Given this list of marker genes TMEM241, CHEK1, TROAP, GINS1, PKIB, INCENP, SLC22A5, POLE2, DSCC1 (DNA replication and sister chromatid cohesion 1), TMPO, SULF1, SPAG5, PRC1, CIT, TMEM120B, BRI3BP, BIRC5, CENPJ, NME1, CDCA7, FIGNL1, MASTL, CNIH2, WDHD1, NXNL2, CBX5, MYBL1, AURKA, MRE11, DEGS2, MMS22L, MAP6D1, ASPM, NCAPD2, LSM4, HAUS8, CD320, H2AX, ZWILCH, KCNK5, SIAH2, LYPD6, ESPL1, STIL, MYB, NCAPG2, H1-2, NEMP1, NFATC2, E2F8, XYLB, CIP2A (cellular inhibitor of PP2A), TOP2A, BCL2, CTSD, ELOVL2, KIF23, CDCA4, L2HGDH, KIFC1, SLC39A6, TFDP1, TFAP4, CEP85, NCAPH2, PDSS1, POLD3, JAK2, SYTL5, CDC45, KRT13, FANCG, FANCI, FEN1, MICB, STC2, EXOSC5, BLM, BUB1B, CDK1, RNASEH2A, TMED8, TICRR, ATAD5, CEP55, RFC5, SKP2, MCM6, SMC2, DARS2, SLC7A5, TYMS, AREG, IL17RB, DDX10, MCM5, ABHD2 (abhydrolase domain containing 2, acylglycerol lipase), SLC26A2, RECQL4, NRIP1, PCP4, PKMYT1 (NCBI Gene Id 9088), E2F1, RBL1, MCM3, CDCA7L, BRCA1, KNSTRN, FAM83D, CENPU, DUT, GINS2, VRK1, UHRF1, IL1RAP, REXO5, POLA1, SNRNP25, FREM2, RFC2, MCM2, TENT5C, CLSPN, SUV39H1, STMN1, MELK, RAD54B, SKA3, RAD54L, COL12A1, RFC4, LIG1, EPS15L1, IGFBP4, DNMT1, KCNK15, RAPGEFL1 (NCBI Gene Id 51195), SHCBP1, CENPI, NPY1R, CENPL, ARMCX6, KIF2C (kinesin family member 2C), PAQR4, DHRS2, E2F7, NASP, DHTKD1, ARL3, GGH, MTFR2, TRIP13, RPA3, PGR, POLE, TPX2, CENPM, GMNN, C1QTNF6, POLQ, EXO1, IMPA2, MANEAL, RACGAP1, SLC29A1, POLA2, MCM4, CCNB2, JPH1, FOXM1, MTHFD1, ATAD2, FBXO5, RET, TST, MGP, TMEM38B, DEPTOR, ARHGAP11A, H19, CA12, TIMELESS, KNL1, PBK, ZWINT, CHTF18, SLC27A2, DSN1, HR, FKBP4, HPRT1, MYO19, CENPO, E2F2, SPDL1, TK1, CDCA2, FKBP5, CHRNA5, CHPT1, RAD51, POLD2, CCNE2, GLB1L2 (galactosidase beta 1 like 2), KIF4A, ASF1B, RRM1, PLK4, TONSL, SGK3, LRIG1, PRIM1, WDR62, AMZ1, SFXN2, TREX2, PCNA, KNTC1, MCM10, DNA2, MPHOSPH9, MAN1A1, POLD1, UBE2T, NUSAP1, MCM8, CXCL12, RRM2, AURKB (aurora kinase B), CDK2, BARD1, NCAPD3, GINS3, GTSE1, COLGALT1, CENPN, RERG, KCNK6, CELSR2, DCLRE1B (DNA cross-link repair 1B), TFF1, BRCA2, CEP78, FANCC, NHERF1, UBE2C, NOS1AP, DSCAM, IQGAP3 (NCBI Gene Id 128239), RFC3, CHAF1A, PCLAF, STC1, TMEM164, BRIP1, DYNC2I2 (NCBI Gene Id 89891), RAB31, TET2, RBBP8, CCDC34, DDIAS, MIS18A, FAM111B, DEPDC1B, XRCC3, NUP85, SLC39A8, PLK1, CDT1, CCN5, BUB1, ADCY1 (adenylate cyclase 1), MCM7, C21orf58, H1-4, NUP107, SPC24, GFRA1, GREB1, SLC2A1, FANCA, TCF19, NCAPG, RAD18, EXOSC2, RMI1, PTTG1, CCNA2, PRR11, EBP, SEMA3B, TPD52L1, ZNF367, PSMC3IP, XRCC2, TTF2, CDCA5, UNG, FANCD2, DLGAP5, NCAPH, CDC6, NR2C2AP, DTL, CHAF1B, TRAIP, WDR76, LRR1, LMNB1 (NCBI Gene Id 445266), PPIF, GAS2L3, SUV39H2, TTK, HAUS4, KIF11, GLA, MKI67, TACC3, MYBL2, XBP1, ANLN, ESCO2 (NCBI Gene Id 5951), HELLS, here is a description of the gene set: from publication Dutertre M, Gratadou L, Dardenne E, Germann S, Samaan S, Lidereau R, Driouch K, de la Grange P, Auboeuf D (PMID 20406972) studied in species Homo sapiens Genes up-regulated in MCF7 cells (breast cancer) at 24 h of estradiol treatment. Alternative promoters (AP) occur in >30% protein-coding genes and contribute to proteome diversity. However, large-scale analyses of AP regulation are lacking, and little is known about their potential physiopathologic significance. To better understand the transcriptomic effect of estrogens, which play a major role in breast cancer, we analyzed gene and AP regulation by estradiol in MCF7 cells using pan-genomic exon arrays. We thereby identified novel estrogen-regulated genes (ERG) and determined the regulation of AP-encoded transcripts in 150 regulated genes. In <30% cases, APs were regulated in a similar manner by estradiol, whereas in >70% cases, they were regulated differentially. The patterns of AP regulation correlated with the patterns of estrogen receptor alpha (ERalpha) and CCCTC-binding factor (CTCF) binding sites at regulated gene loci. Interestingly, among genes with differentially regulated (DR) APs, we identified cases where estradiol regulated APs in an opposite manner, sometimes without affecting global gene expression levels. This promoter switch was mediated by the DDX5/DDX17 family of ERalpha coregulators. Finally, genes with DR promoters were preferentially involved in specific processes (e.g., cell structure and motility, and cell cycle). We show, in particular, that isoforms encoded by the NET1 gene APs, which are inversely regulated by estradiol, play distinct roles in cell adhesion and cell cycle regulation and that their expression is differentially associated with prognosis in ER(+) breast cancer. Altogether, this study identifies the patterns of AP regulation in ERGs and shows the contribution of AP-encoded isoforms to the estradiol-regulated transcriptome as well as their physiopathologic significance in breast cancer. Human Gene Set: DUTERTRE_ESTRADIOL_RESPONSE_24HR_UP